The following is a description of a gene set: studied in species Homo sapiens part of: Signaling by TGFBR3 This subpathway describes the regulation of FGF2:FGFR1 mediated signaling by the TGFBR3 receptor complex. TGFBR3 have binding affinity for FGF2 and in presence of GIPC, FGF2/TGFBR3/GPIC enhances FGF2 signaling (Knelson et al.,2013). Reactome Pathway: TGFBR3 regulates FGF2 signaling, and this is the list of marker genes: FGF2, TGFBR3, GIPC1